Given this list of marker genes RIT1, GREB1L, MRAS, SOS1, SEMA3E, NRAS, SOS2, RRAS, SOX10, CHD7, FGFR2, SIX5, KMT2D, LZTR1 (leucine zipper like post translational regulator 1), KRAS, KDM6A, ESRP1, FOXP2, RRAS2, SPRED2, SIX1, RASA2, CBL, RAF1, EYA1, PTPN11, here is a description of the gene set: An abnormality of the morphology of the semicircular canal. Abnormal semicircular canal morphology species: Homo sapiens Human Gene Set: HP_ABNORMAL_SEMICIRCULAR_CANAL_MORPHOLOGY